Given this list of marker genes Bahd1, Atxn1, Chm, Atosb, Mob3b, Asb15, 0610030E20Rik, Synpo, Sh3bgr, Arl14epl, Vstm4, Mettl9, Ipo8, Fhip1b, Clcn4, Gata2, Rab28, Prickle2, Gm9, Rnpc3, Metap1, Mtx3, Slc5a3, Zfp592, Irf2, Kcne4, Tmprss3, Ceacam20, Ppm1h, Trp73, Ndufaf5, Aff4 (AF4/FMR2 family, member 4), Srrm2 (serine/arginine repetitive matrix 2), Homer1, Commd6, Glra1, Rbm14, Lrrc8e, Chrm1, Aifm3, Zfp712, Ccdc71l, Raph1, Traf6, Zdbf2, Cacna2d1, Hs3st5, Sulf2, Nfasc, Cers6, Ccdc93, Kcnv2, Vdr, Rtbdn, Aak1, Btc, Syt5, Stc1, Prokr1, Adam30, Lyn, Flrt1, Ptprt, Vangl1, Hs3st3b1, Fam120c, Grm5, S1pr3, Casc3 (exon junction complex subunit), Gdap1l1, Rarg, Cyb5r2, Zfp872, Ino80d, Cramp1, Dlg3, Mcm6, Ppm1d, Slc23a4, Atp1b2, Ets1, Zbtb20, Cd83, Ggt7, Ncaph, Prob1, Rora, Gpd1, Inava, Cp, Eef1akmt1, Ncoa4, Wdr72, Necap1, Spock1, Dock5, Trio, Adra1a, Bco1, Sh3rf3, Slamf7, Meox1, Faxc, Hacd4, Ntng1, Ednra, Timp3, Mrpl3, Sh2d1b1, Sash1, Fgf9, Tafa5, Smim7, Kpnb1, Ntsr1, Npas3, Foxn2, Vcl, Shisa7, Prrg3, Appbp2, Cwf19l1, Myocd, Cdh3, Neurog2, Slc22a28, Vps26c, Zer1, Pear1, Pafah2, Sirt2, Acsf2, Tnrc6b, Ip6k1, Setdb1, Phf2, Fn1, Palm, Arhgap32, Tfg, Tmc5, Idh1, Kirrel3, Cfl2, Pla2g4f, Cpeb1, Cdk19, Usb1, Gpatch8, Lmcd1, Cd209e, Steap4, Ddias, Inka2, Crot (NCBI Gene Id 74114), Xaf1, Cnnm1, Pip4k2a, here is a description of the gene set: species: Mus musculus from publication Chen Y, Wang X (PMID 31504780) Genes predicted to be targets of miRBase v22 microRNA mmu_miR_7684_5p in miRDB v6.0 with MirTarget v4 prediction scores > 80 (high confidence targets). Mouse Gene Set: MIR_7684_5P